Given this list of marker genes VEGFA, SFRP4, APELA, PLCG2, APP, CD63, GH1, INSR, APLNR, DRD2, FMR1, PICK1, GREM1, EGF, ATAD1, SYK, DTNBP1, AHI1 (NCBI Gene Id 54806), ANGPT1, TBC1D5, MAGI2, ARRB2, AP2M1, APLN, NTF3 (NCBI Gene Id 4908), ARRB1, PCSK9, SELE, WNT3A, HAMP, here is a description of the gene set: studied in species Homo sapiens Human Gene Set: GOBP_POSITIVE_REGULATION_OF_RECEPTOR_INTERNALIZATION Any process that activates or increases the frequency, rate or extent of receptor internalization.